Given this list of marker genes Babam2, Babam1, Brcc3, Shmt2, Abraxas2, Brcc3dc, Mpnd, here is a description of the gene set: Mouse Gene Set: GOCC_BRISC_COMPLEX species: Mus musculus A protein complex that contains the FAM175B/ABRO1, BRCC3/BRCC36, BRE/BRCC45 and MERIT40/NBA1 proteins, and specifically cleaves K63-linked polyubiquitin chains.